Given this list of marker genes Lamtor5, Rps6, Tsc1, Prkag3, Rragc, Lamtor2, Akt1s1, Rheb, Eif4ebp1, Rps6kb1, Fkbp1a, Lamtor1, Prkag1, Rraga, Lamtor4, here is a description of the gene set: species: Mus musculus electronically inferred by orthology from the curated human pathway This event has been computationally inferred from an event that has been demonstrated in another species.<p>The inference is based on the homology mapping from PANTHER. Briefly, reactions for which all involved PhysicalEntities (in input, output and catalyst) have a mapped orthologue/paralogue (for complexes at least 75% of components must have a mapping) are inferred to the other species. Reactome Pathway: MTOR signalling part of: Signal Transduction